The following is a description of a gene set: Human Gene Set: GOBP_MOTILE_CILIUM_ASSEMBLY studied in species Homo sapiens The aggregation, arrangement and bonding together of a set of components to form a motile cilium., and this is the list of marker genes: CFAP47, CEP131, DRC7, E2F4, PFN4, CFAP206, RSPH6A, SPAG16, BBS5, LRRC46, CFAP57, SPAG6, CENPJ, AKAP4, MKS1, DNAAF3, DYNLL1, JHY, PLA2G3, POC1B, TTC12, AHI1, DNAAF11, YIF1B, ENKD1 (NCBI Gene Id 84080), SPEF2, DNALI1, CCDC38, PDCL2, CCDC159 (coiled-coil domain containing 159), CFAP53, CEP128, MNS1, CFAP54, TTLL5, BBOF1, KLC3, DMD, CFAP58, DNAAF1, INTU, CFAP97D1, SPATA6, IQCG, CFAP43, GK2, IFT81, RSPH9, DRC1, CFAP221, ARMC12 (armadillo repeat containing 12, NCBI Gene Id 221481), CFAP65 (NCBI Gene Id 255101), CFAP69, DNAH1 (NCBI Gene Id 25981), DZIP1, SPAG17, ARMC2, NEURL1, FSIP2, ZMYND12, CCDC146, MEIG1, NOTO, CC2D2A, CFAP119, ZMYND10, MCIDAS, TTLL1, CCDC40, VDAC3 (NCBI Gene Id 7419), CCDC39, FOXJ1, ATMIN, TPGS1, BBS4, BBS2, DNHD1, CFAP157, CFAP44, IFT57, CFAP61, TBC1D21, UBE2B